The following is a description of a gene set: studied in species Homo sapiens part of: Infection with Enterobacteria Reactome Pathway: Action of antimicrobials and antimicrobial resistance This pathway combines the Action of antimicrobials and Antimicrobial resistance pathways., and this is the list of marker genes: 16S rRNA, tetA, KPC-2, rrsA, macB, rmtF, gyrB, mdfA, gdx, tetB, rmtD, pef, blaSHV-12, rmtC, bla, rmtG, rmtH, armA, macA, tolC, emrE, mdtE, AAC(6')-Ib, qnr, acrA, mrcB, rmtB, mdtF, oqxA, gyrA, acrB